The following is a description of a gene set: Genes up-regulated in comparison of eosinophils versus neutrophils. species: Homo sapiens from publication Jeffrey KL, Brummer T, Rolph MS, Liu SM, Callejas NA, Grumont RJ, Gillieron C, Mackay F, Grey S, Camps M, Rommel C, Gerondakis SD, Mackay CR (PMID 16474395) Human Gene Set: GSE3982_EOSINOPHIL_VS_NEUTROPHIL_UP In the present study we used Affymetrix oligonucleotide microarrays to produce gene transcription profiles for the major leukocyte types in humans. This comprehensive dataset enabled us to not only establish which genes were expressed in each leukocyte type, but also which genes were expressed in each subset after activation. The used of a comprehensive dataset of gene profiles from all the major human leukocyte subsets enabled a novel and powerful means for identification of genes associated with single leukocyte subsets, or different immune paradigms., and this is the list of marker genes: MRPL9, SIAH1, EDDM3A, GPR35, RREB1, API5, ZC3H14, PIGH, SSX2IP, GOLGA8B, LSM4, DMAC2L, ABRAXAS2, FAM110B, FUCA1, NFE2L3, POLR3C, FBXO21, SMARCA4, KLRF1 (NCBI Gene Id 51348), PCNX2, CD244, TPMT, RRP7A, KRTAP1-1, TOLLIP, TCF25, TNNI3, RNASE2, HARS2, CPA4, EIF5B, RPL9, YBX1, PSMD1, NFX1, NUDT4 (nudix hydrolase 4), THBS4, TRMT1L, ALOX15, ADI1, NUP37, PKD1P6, POLR3E, GCNT1, CLASP2, MC4R, DDX21, MGST3, PDE4A, HES1, ABCA1, MRPS30, CDYL, MRM2, CDC37, DIABLO, LYRM2, COPS5, TTF2, NUP205, RPS4X, MAIP1, CLTC, PHF10, TRIM44, RNMT, STAM, CLNS1A, RTCB, MTO1, DBR1, GLOD4 (NCBI Gene Id 51031), NRBP1, NDUFAB1, ZNF276, SCN2B (NCBI Gene Id 6327), TNFSF11, PTPRO (protein tyrosine phosphatase receptor type O), HNRNPA0, EPAS1, ARRB1, ZCCHC14, MEX3C, PRDX1, LAMTOR5, CAMTA1, ZNF460, GIPC2, MYH1, TMEM131, WDR3, SSB, BFAR (bifunctional apoptosis regulator), GPN3, RAN, UBB, GOLT1B, RPS6KA2, TARS1, DROSHA, CFDP1, MRPL16, SRRT, PUS1, ARL2, NUP155, INPP5F, TGDS, ABCD1, NEK4, CSRP1, FNTB, ANXA1, MTCP1, C11orf58, ZNF432, CRNKL1, CCL23, FAM162A, DEXI, GOSR2 (golgi SNAP receptor complex member 2), C1orf115, ACP3, AREG, PSORS1C1, SMC5, ABHD2, DOK2, GOLIM4, ACAA2, TCF12, FASTKD3, PRPF19, METTL3, AK2, HAT1, TRAPPC13, PEX3, CD8B, BET1, DSC3, MATR3, SIGLEC15, ITM2C, HOXB1, PCNT, GFOD1, PDXDC1, H2AC17, PWP1, SKAP1, POLG, KIT, APPBP2, TYW1, USP36, DOCK10, CD1E, C17orf75, ITGB3BP (integrin subunit beta 3 binding protein), RNH1, EIF4B, GPN1, CAPN15, NUP50, COMMD3, UBA3, IPCEF1, RAP1GDS1, MAGOH, JOSD1, RERGL, FBL, CCNC, FAN1, ACAD8, VHL, PPARD, SEC62, LRIG1, LINC01565, ZCCHC24, MRPL40, PKD1P1, ARFGAP2, YTHDC2, RASSF1, S1PR1, CLIP3, CNTRL, TOMM70, PPP1R26, FAM118A, COIL, DMXL1 (Dmx like 1), CD164, HSPA1L, FAM136A